The following is a description of a gene set: Signaling by membrane-tethered fusions of PDGFRA or PDGFRB studied in species Homo sapiens Human Gene Set: REACTOME_SIGNALING_BY_MEMBRANE_TETHERED_FUSIONS_OF_PDGFRA_OR_PDGFRB, and this is the list of marker genes: GOLGA4, ETV6, KDR, KANK1, BIN2